The following is a description of a gene set: studied in species Mus musculus Genes positively differentially expressed in cell type: CD4+ T cell upon treatment with cytokine: TL1A in mouse lymph nodes in vivo. from publication Cui A, Huang T, Li S, Ma A, Pérez JL, Sander C, Keskin DB, Wu CJ, Fraenkel E, Hacohen N (PMID 38057668) Cytokines mediate cell-cell communication in the immune system and represent important therapeutic targets. A myriad of studies have highlighted their central role in immune function, yet we lack a global view of the cellular responses of each immune cell type to each cytokine. To address this gap, the authors created the Immune Dictionary, a compendium of single-cell transcriptomic profiles of more than 17 immune cell types in response to each of 86 cytokines (>1,400 cytokine-cell type combinations) in mouse lymph nodes in vivo. A cytokine-centric view of the dictionary revealed that most cytokines induce highly cell-type-specific responses. For example, the inflammatory cytokine interleukin-1β induces distinct gene programmes in almost every cell type. A cell-type-centric view of the dictionary identified more than 66 cytokine-driven cellular polarization states across immune cell types, including previously uncharacterized states such as an interleukin-18-induced polyfunctional natural killer cell state. Mouse Gene Set: CUI_T_CELL_CD4_TL1A_RESPONSE_UP, and this is the list of marker genes: H2-K1, Fas, Nfkb1, Sting1, Gbp2, Sumo2, Psme2 (proteasome (prosome, macropain) activator subunit 2 (PA28 beta)), Ikzf3, Il2rg, Stx6, Abcc1, Tapbp, Hivep1, G3bp1, Tnfrsf18, Pofut1, Tesc, Batf, Ltb, Tnfrsf9, Relb, Psmb10, Vars1, Gramd2b, Ptp4a2, Rara, Stap1 (signal transducing adaptor family member 1), Kmt2a, Irf2bp2, Trp53, Kdm2b, Icam1, H2-Q7, Atp1b1, Ptpn6, Ifi203, Kif1b, Cmtm7, Mndal, Tnfrsf4 (NCBI Gene Id 22163), Sms, Tnfaip3, Zmiz2, Cd52, Nfkbia, Sdhaf1, Zc3h12a, Mvp, Cd82, Ifi47, Tnfrsf25, Rrad, Grap, Atr, Cd83, Bcl3, Parp14, Limd2, Ly6a, Tgfb1, Nfkb2, Eif5a, Nfkbie, Lta, Zfp36l1, Rel, Cd4, B2m, Stat1, Ptma (NCBI Gene Id 19231), Ier5, B4galnt1, Gadd45b, Vps28, Tyk2, Psme1, Tank, Tnip1, Jak2, Ctss, H2-Q4, Bst2, Aebp2, Apobec3, Fam169b (family with sequence similarity 169, member B), Tapbpl, Tuba1b, Ppp1r11, Irf1, Mapkapk2, Btg1, Traf1, Ikbke, Ms4a4c, Pou2f2, Cyba, Creb1, Calr, Inf2, Ly6e, Csrp1, Tmsb10, Ncf4, Gbp4, Med11, Jpt1, Shisa5, Cdc37, Birc3